Given this list of marker genes SLC12A2, CXCL11, ADAM17, CXCL12, CCL5, CXCR3, DEFA1, CXCL10, WNK1, OXSR1, CXCL16, GPR183, STK39 (serine/threonine kinase 39), ADAM10, DEFA1B, XCL1, CCL21, CCR2, PIK3CG, PLEC, PIK3CD, TMEM102, TNFSF14, CXCL13, CCL3, DEFA4, CCL26, WNT5A, S100A7, here is a description of the gene set: The directed movement of a T cell in response to an external stimulus. A T cell is a type of lymphocyte whose defining characteristic is the expression of a T cell receptor complex. species: Homo sapiens Human Gene Set: GOBP_T_CELL_CHEMOTAXIS